Given this list of marker genes FAM120C, PAG1, MS4A7, TRAPPC11, PDCL3 (NCBI Gene Id 82833), PHKB, NSDHL, SHLD1, ZNF583, TBC1D19 (TBC1 domain family member 19), BICRA, SNTA1, GSN, TSPAN15, TMEM86B, CAB39L, CACNA1H, HIVEP2, COL5A2, NFATC2IP, AMOTL2, LTK, KBTBD7, LRSAM1, PHC3, CAPN15, SCYL1, HMGCR, RPAP2, MPEG1, FGD6, KCNV1, LPIN3, MYL4, L3MBTL3, IL1RAPL1, MFF, C11orf97, MPZL3, PIK3CG, ZDBF2, CCDC160, PBX3, ALOX12B, ITGAV, ANKRD54, PMEPA1, BOK, CCDC117, USO1 (NCBI Gene Id 8615), ZDHHC23, ATE1, SRGAP1, INPP5B, RUNX1T1, CSGALNACT1, TUT4, FHOD1, SLC17A5, LRATD2, BHMT (betaine--homocysteine S-methyltransferase), KRT222, LATS1, GPRIN2, HDHD2, ENPP3, ITGA2, NCOA4, CRACD, ATXN7, TBK1, C4orf54 (chromosome 4 open reading frame 54), BCLAF3, TAF2, TPD52L1, MTF1, SLC30A9, ABLIM1, ZNF592, FAM13B, WAPL, ZNF2, CLPTM1L, BMP2, MDFIC (MyoD family inhibitor domain containing), NPR2, H1-8, ZNF180, CCDC127, MAN1A1, APEX2, ASCL1, NTF3, MMP11, DCLRE1C, RASA2, RLIG1, PLPP6, DMRTC2 (DMRT like family C2), CFAP20DC, GPR22, HEXD, CNOT8, JAZF1, DUSP22, ARL6IP6, MBL2, IMPA1, SAT1, PRKAA1, MED28, CTRL, IL18R1, INVS, STXBP3, LPIN2, IDS, GML, CYP26A1, RETREG1, SPATA18, ERGIC2, USP15, RIT1, CHD1L, HGFAC, TMEM81, EAF2, MAGI3, TMEM41B, SERP1, GPRASP1, GABRD, SP1, CHST11, FBXO11 (F-box protein 11), NARF, AKAP6, SLC4A7, CCDC181 (NCBI Gene Id 57821), TRABD2B, BBS5, SH3BGRL, ZFP36L1, IL6ST, CLN5, SLC31A1, TMF1, CLEC4G (C-type lectin domain family 4 member G), BEND5, PIKFYVE, ATG4D, DNMBP, SCN8A, RPS21, SNAI1 (NCBI Gene Id 6615), P2RY12, TBC1D5, CD79A, SWAP70, MCM3AP, GRK3, SLC9A9, SLC7A6OS, TAFA3, ANXA4, TPCN1, SEMA5A, SOAT1, EEIG1, AMN1, PRR13, GGH, SPAG9, TMED7, RUNDC3B, CD84, TRHR, TMEM269, CAAP1, ICOS, VPS26A, OMA1, STARD4, XIST, MTSS1, CPNE8, OSBPL8, MPZL2, YEATS4, NDUFA4, CLCA1, WIF1, PTPN14, CAPS2, EEA1, GPR137B, CETN2, GOPC (NCBI Gene Id 57120), TMED6, here is a description of the gene set: studied in species Homo sapiens Influenza virus infection-induced gene expression changes of regional B cells are mediated at least in part through type I Interferon: Our objective is to determine whether the influenza virus-infection induced gene expression changes in regional lymph node B cells are facilitated at least in part through type I interferon. Our specific aim is to compare the gene expression profile of highly FACS-purified B cells in the regional lymph nodes of wildtype and IFNR-/- mice prior to and 48h following infection with influenza virus infection and to contrast this expression profile with that of FACS-purified wildtype B cells activated in vitro with IFN-beta +/- anti-CD86 for 12h. Genes up-regulated in lymph node B lymphocytes: untreated versus interferon beta. from publication Chang WL, Coro ES, Rau FC, Xiao Y, Erle DJ, Baumgarth N (PMID 17237394) Human Gene Set: GSE3203_UNTREATED_VS_IFNB_TREATED_LN_BCELL_UP